Given this list of marker genes HNRNPA2B1 (heterogeneous nuclear ribonucleoprotein A2/B1), YTHDF1, ALYREF, TIAL1, SH3BGRL (NCBI Gene Id 96022), YTHDF2 (NCBI Gene Id 63042), IGF2BP2, ZFP36, SRSF3, DGCR8, QKI, YBX1, RBM33, IGF2BP1, ZNF598, C1QBP, YTHDF3, FMR1, YTHDC2, YTHDC1, IGF2BP3, HNRNPC, LIN28A, here is a description of the gene set: Human Gene Set: GOMF_PROTEIN_RNA_ADAPTOR_ACTIVITY species: Homo sapiens The binding activity of a protein that brings together another protein and an RNA, permitting those molecules to function in a coordinated way.